The following is a description of a gene set: Mouse Gene Set: GOBP_PROTEIN_CONTAINING_COMPLEX_ORGANIZATION species: Mus musculus Any process in which macromolecules aggregate, disaggregate, or are modified, resulting in the formation, disassembly, or alteration of a protein complex., and this is the list of marker genes: Pnpt1, Aif1, Crtc3, Gemin8, Mcts2, Llgl1, Rpl10l, Kcnf1, Arid1a, Map4, Mtrfr, Odad3, Dnm2, Mzb1, Arf6, Abca1 (ATP-binding cassette, sub-family A member 1), Kcng3, Dnah8, Trappc2, Prmt7 (protein arginine N-methyltransferase 7), Nckap1, Pde4d, Katnb1, Mavs, Flii, Tekt2, Eif3i, Atp5mc2, Kctd1, Pml, Plekha7, Dnajb12, Diaph2, Csnk1d, Per2, Cenpw, Map2, Cptp, Sh3bp1, Rab5if, Aldh1a3, Rpsa, Prkd1, Rpl24, Npm1, H1f6, Micu1, Clta, P2rx3 (NCBI Gene Id 78804), Trappc2l, Capg, Smarcd2, Cav3, Padi4, Rubcn, Pwp2, Trappc3, Gspt1, Med16, Pdcd6, Fus, Wnk1, Ublcp1, Denr (density-regulated protein), Large1, Dstn, Mlst8, Usp4, Capza1b, Ndufa13, Samhd1, Plek, Ndufa10, Cdc42, Pycard, Oprd1, Ube2c, Sorl1, Hes5, Sun5, Cracd (NCBI Gene Id 75147), Trappc5, Cops8, Shank1, Lima1, Sod2, Chmp4c, Fadd, H2-Ea, Kcnj12, Pcdhga3, Map7d3, Bok (BCL2-related ovarian killer), Plec, Rbpms, Traf3ip1, Ptpn11, Lrrk2, Brsk1 (BR serine/threonine kinase 1), Bnip3, Bbof1, Rack1, Capn3, Mtln, Fes, Rictor, Dele1, Stmn4, Pole3, Bend3, Gsdmd, Ryr3, Fscn1, Sar1a, Wdr77, Picalm, Eps8, Prpf18 (pre-mRNA processing factor 18), Pak3, Ggn (gametogenetin), Nrg1, Vps4b, Myadm, Zmynd10, Rcc1l, Myc, U2af2, Coro7, Lyrm7, Tssc4, Trim54, Cenpo, Rp1, Gemin2, Mapk8 (NCBI Gene Id 26419, mitogen-activated protein kinase 8), Syp (synaptophysin), Psmg3, Tmem39a, Ago1, Cntln, Tapbp, Atad2b, Hmgb1, Ccl21b, Usp50, Med23, Med4, Psip1, Rasa1, Ccdc88c, Cenph, Mpp7, Chp1, Dbn1, Brf1, Bin1, Med15, Coa4, Celf3, Uqcrc1, Ikbkg, Naf1, Cbr4, Tubb4a, Hcn1 (NCBI Gene Id 319874), Taf11, Smarca2 (NCBI Gene Id 67155), Card11, Nsg2, Aqp5, Kmt2a, Fmn1, Prex1, Ndufs5, Fnip2, Gtf2h5, Taf7l, Kcnq2 (NCBI Gene Id 16536), Arfgef1, Ppp1r9a, Znhit3, Cd247, Taf10, Tnfaip1, Ndufb11b, Nup35, Raf1, Otx2, Ccdc65, Taf4, Tmem186, Taf12, Tk1, Acvr1c, Axin1, Timm21, Gch1, Hcls1, Tnfsf18, Lrp12, Kcnq3, Slc31a1, Chmp2b, H1f5 (H1.5 linker histone, cluster member), Ddx42, Setx, Clec7a, Pak1, Casp4, Sf3a1, Tmem120b, Kcng4, Mrpl58, Hacd1, Tespa1, Lcat, Kctd2, Eif4g1, Jam3, Crnkl1, Aurkb, Vegfa, Ptger4, Zfand1, Rbmx, Stx1b, Atp6ap1, Mrps7, Uqcc4, Pet100, Nefm, Appl2, Higd2a, Ndel1, Eif2d, Bik, Med21, Sv2a, Mlkl, Erc2, Bbs10, Capzb (capping actin protein of muscle Z-line subunit beta), Bcs1l, Eif3m, Calhm3, Celf5, Hip1, Cfl2, Mdn1, Slc25a46, Tfam, Asb2, Srsf1, Daw1, Pla2g12b, Eif3j1, Basp1, Chmp3, Zfp207, Stx4a, Cox7a1, Kank2, Ncln, Kcna1, Sec16a, Ndufb1, Diaph1, Unc13d, Sh3gl2, Cryaa, Med22, Acacb, Kcns2, Pik3ca, Ddx28, Abca5, Tifa, Prpf3, Adgrl4, Ube2s, Bax, Hsp90ab1 (NCBI Gene Id 98078), Mecp2, Srsf10, Trpm4, Bdp1, Samd1, Pfn1, Wnt10b, Dnaaf10, Bag4, Ppp2r5b, Csf2, Chmp7, Ccdc39, Rad51c, Nlrc3, Higd1b, Pym1, Ssh2, Dmtn, Fermt3, Ifih1, Lyrm2, Hccs, Tmsb15l, Ube2srt, Preb, Kcnd3, Ndufs3, Kcna7, Coro1a, Eef2k, Farsa, Ripor2, Zfp827, Rho, Ccl21a, Chd2, Tnp1, Clns1a, Tcf4, Stk3, mt-Nd4, Mpo, Rnf112, B2m, Nrxn1, Chmp1b2, Ndufs8, Eif5, Vcp (valosin containing protein), Kcnb2, Aimp2 (aminoacyl tRNA synthetase complex-interacting multifunctional protein 2), Eral1, Coa5, Abitram, Actr3, Erc1, Ap1b1, Dkc1, Cenpi, Spef1, Rps27, Kcng1, Prpf6, Fyco1, Csnk1a1, Uqcc3, Shmt2, H1f2, Ndufc1, Cul3, Fermt1, Phf23, Ikzf1, Mapk15, Tubgcp5 (NCBI Gene Id 259278), Alox5ap, Ap2b1 (adaptor-related protein complex 2, beta 1 subunit), Gemin6, Ndufab1-ps, Tubb1, Ndufaf8, Scarb1, C9, Mapk9, Chchd4, Oas1e, Vamp4, Gas7, Nlrc4, Ndufb6, Ndufs2, Stmn1, Srpk1, Hax1, Togaram1, Nol3, Tspyl1, Pcnt, Sdhaf1, Ehd4, Gsdma3 (NCBI Gene Id 450219), Ago3, Nup98, Epn1, Dnah2, Tuba1a, Tmsb15b2, Nr1h2, Apob, Spp2, Nup93, Ubqln1, Unc13a, Fermt2, Lipg, Mical2, Vbp1, Bad, Ifi214, Clasp2, Snap25, Git1, Kctd10, Mis18a, Ptges3l, Fnip1, Bin2, Brix1, Synj1, Trim30a, Tmod4, Dnah7a, Cfl1, Upf1 (UPF1 RNA helicase and ATPase), Bid (BH3 interacting domain death agonist), Camsap3, Cttn, Oip5, Ext1, Tppp3, H1f0, Ckap2, Usp16, Rph3a, Abl1, Ndc1, Dock5, Ttc17, Calr, Lix1, Dmc1, Ric3, Tirap, Snx14, Ripk1, Trem2, Ppp2ca (protein phosphatase 2 (formerly 2A), catalytic subunit, alpha isoform), Prpf39 (pre-mRNA processing factor 39), Trim31, Ndufb2, Nedd1, Casq2, Kirrel1, Pard6b, H1f9, Pip4p1, Vamp3, Dnaaf3, Ankra2, Ninj1, Comp, Ap2m1, Lcmt1, Mapk3, H3f3c, Etf1, Hrk, Lmod1, Ube2k, Ccl24, Eml2, Cenpe, Mospd2, Sh3pxd2b, Stx1a, Ddit4, Kcnd2, Yap1, Srp19, Casq1, Mip, Epb41, Eif3g, Pfdn5 (prefoldin 5), Baiap2, Vps33a, Prpf4b, Adam10, Napb, Esr1, Mrto4, Mbl1, Acot13, Ndufaf6, Ppp1r9b, Gsk3b, Itpr1, Mark4 (MAP/microtubule affinity regulating kinase 4), Pfdn6, Kif21a, Atr, Sdhaf4, Pla2g7, Arhgap28, Kif2c, Chaf1b, Snap91, Hdgfl3, Setd2, Oxa1l, Lrrc8a, Slc1a5, Mttp, Nsf, Hjurp, Ndufs1, Trim21, Arpc4, Nlrp1b, Trim72, Lpl, Specc1l (sperm antigen with calponin homology and coiled-coil domains 1-like), Eif3e, Ankrd53, Slc24a2, H2-Aa, Fer, Nap1l5, Krt10, Trpm6, Pdxp, H2-Eb1, Ndufa1, Mzt1, Shmt1, Ikzf4, Evl, Adrb2, Anks4b, Mettl17, Abt1 (activator of basal transcription 1), Vdac2, Pkd2, Krt1, Chchd10, Mtpn, Ndufa11b, Hopx, Taf5, Rrs1, Dnai2, Cox17, Clint1, Nap1l4, Dhx30, Asf1b, H4c14, Lats2, Dnah7c, Nek7, Plekhg2, Aldob, Glra3, Ruvbl2, Ttbk1, Insr, Unc13b, Shroom2, Pcsk5, Osbpl2, Taf13, Trpa1, Psmd11, Cobl, Brd2, Ptpn22, Taf3, Cadps2, Vil1, Gpihbp1, Cenpa, Ptk2 (NCBI Gene Id 14083), Gmnn, Spast, Chmp4b, Atl1 (atlastin GTPase 1), Calm3, Tlr2, Zdhhc1, Srpk3, Ddx46, Tap2, Cck, Clasp1, Cops7a, Selp, Sppl2c, Col16a1, Lrrc8c (leucine rich repeat containing 8 family, member C), Vwa1, Hprt1, Ifi206, Ssna1, Apc2, Cox18, Ifi213, Hey2, Cp, Fbxl2, Cdc42ep4, Mtor, Mcoln1 (NCBI Gene Id 94178), Kcnc2, Avil, Eln, Kcnn4 (potassium intermediate/small conductance calcium-activated channel, subfamily N, member 4), Hip1r, Apoa5, Pkd2l1, Mtss1, Ccl26, Mical1, Dyrk3, Rsf1, Cdc42ep1, Dact1, Tmod3, Eml4, Riok3, Drc1, Stk4, H2-DMb2, Cep89, Prkn, Ccdc66, H1f1, Ifi208, Psmc6, Arhgef2, Lrrc23, Tecpr1, Map3k7, Col1a2, Cav1, Cby1, Terf1, Calm1, Rims1 (regulating synaptic membrane exocytosis 1), Insm1, Gba2, Sumo1, Elp2, Rsrp1, Kcnc1, Camsap1, Rubcnl, Nap1l2, Clybl, Nfkbiz, Gcfc2 (NCBI Gene Id 330362), Taf1b, Adar (NCBI Gene Id 99861), Dnah7b, Prpf31, Atp23, Lix1l, Med29, Xaf1, Igf1r, Eif3j2, Cox7a2, Smarcd3, Kcna2, Clxn, Stmn2, Chmp6, Rab3a, Hp1bp3, Apip, Apoa2, Creb1, Mefv, Mcu, Ehd3, Tdo2, Smarcb1, Dr1, Rrm1, Luc7l3, Mcm2, Oas1b, Sptbn4, Kif24, Supt6, Kcnv2, Ttc39aos1 (NCBI Gene Id 102642299), Oma1, Tcap, Sh3glb1, Tal1, Fhod3, Micall2, Mid1ip1, Prnp, Plekhh2, Cdc45, Prnd, Ogfod1, Nme7, Pde4dip (phosphodiesterase 4D interacting protein (myomegalin)), Fga, Aldoa, Cdk5rap2 (CDK5 regulatory subunit associated protein 2), Rpf2, Spta1, Ankrd27, Tgfb1, Grwd1, Arl2, Tenm1, Med31, Atxn7, Ubqln4, Tpx2, Taf2, Med24, Sf3a3, Cenpj, Trim11, Pik3r2, Add3, Trpm1, Rhoa, Gldc, Cutc, Trpv6, Ccl21d (C-C motif chemokine ligand 21D), Kcna10, Kcnt1, Prkdc (protein kinase, DNA activated, catalytic polypeptide), Crp, Hemk1, Sirt2, Nefl, Gspt2, Dkk1, Klhl12, Prkra, Pnlip, mt-Nd2, Ctnnbip1, Abcg2, Ugt2b1, Ndufs6, Gtf2b, Nde1, Zdhhc9, Ndufb7, Zw10, Ica1, H2-Oa, Ndufaf2, Bbs4, Cyfip1, Dlgap5, Ambra1, Als2, Odad4, Med18, Faf1, Fkrp, Tmc8, Shkbp1 (NCBI Gene Id 192192), Oga, Tppp, Lsm4, Snap29, Irgm1, Cth, Orc4, Trpv5, Rims2, Vtn, Aifm1, Svip, Nr4a1, Ndufa5, Kcns1, Med10, Coil, Cenpt, Anp32b, Dbnl, Wnt3a, Dnah17, Ifi209, Clip1, Smn1, Snrpf, Twnk, Ccl21f (C-C motif chemokine ligand 21F), Arhgef1, Apoa1, Bcl2l11, Nop53, Svil, Tmem199, Pik3c3, Cyren, Kcnb1, Hsd17b8, Surf1, Hck, Arhgef5, Cfap70, Kctd12, Skap1, Set, Hscb, Mtrf1l, H2-Eb2, Kcns3, Brf2, Prmt5 (protein arginine N-methyltransferase 5), Med7, Atpaf2, Zc3h12a, Tead2, Hnf1b, Ralb, Hspa4, Rsph9, Fau, Cxcl13, H1f4, Dut, Kcnc4, Gabarapl1, Tbcel, Elavl1, Nemf, Blm, Ccdc40, Otud6b, Ttc12, Eif5a2, Rrn3, Tfap4, Ahr (aryl-hydrocarbon receptor), Crtc2, Ndufs4, Myd88, Lmo4, Fech, Ndufb10, Tbp, Jmjd6 (NCBI Gene Id 70547), Lzts3, Cltrn, Fxr1 (NCBI Gene Id 99741), Tln1, Psmg1, Rbmxl1, Rpl11, Hspa8, Wdr47, Smim20, Gtf2f2 (NCBI Gene Id 68705), Pet117, Snupn, Nup153, Mapre1, Pmfbp1, Stxbp6, Uqcc5, Ssrp1, Clec16a, Ehd1, Eif5a, Apoc1, Sar1b, Carmil1, Atf1, Vps4a, Tbc1d25, Rps5, Pias1, Mapre3, Slain1, Stmn3, Pnliprp1, Pf4, Dnah1 (NCBI Gene Id 630521), Sem1, Nup210 (nucleoporin 210), Epg5, Cdc42ep2, Cep57, Trpv4, Vmp1, Ski, Gchfr, Bmerb1, Ang, Casp1, Macroh2a1, Scaf4, Abca7, Med20, Luc7l, Oas1d, Kif18a, Hspa1a, Letm1, Tpm1, Kctd21, Iapp, Abhd17a, Hes1, H1f3, Taf8, Klc1, Dnm1l, Dnaaf4, Wdr1, Syngr3, Kif18b, Ndufc2 (NADH:ubiquinone oxidoreductase subunit C2), Snapin, Scaf8, Pecam1 (NCBI Gene Id 97748), Rad51, Gas2l1, Coa8 (NCBI Gene Id 73501), Snrpert, Il5, Mid1, Met, Nacc2, Isg15, Ndufaf7, Cltc, Cib1, Cd36, Ces1g, Arf1, Sub1, Slc25a33, Sox9, H2-Ab1, Alox15, Srprb, Smarca5, Rps28, Camsap2, Fgb (NCBI Gene Id 67908), Snap23, Eif3f, Cox14, Mndal, Ndufa6, Gm12250, Birc2, Elp6, Mcmdc2, Dnaaf2, Pogz, Chrac1, Dnm1 (dynamin 1), Nopchap1, Smyd3, Nup133, Smcr8, Hsp90aa1, Zmpste24, Ssh1, Kctd16, Farsb, Tmod2, Pih1d2, Celf6, Twf2, Tppp2, Ticam1, Prf1, Nup54, Immp2l, Trappc4, Tafazzin, Tmsb4x, Snrpb, Nin, Eif3b, Spag1, Gemin5, Srsf12, Grin1, Supt16, Asph, Rps6-ps4, Gabarap, Sost, Kctd11, Rps14 (NCBI Gene Id 99773), Kctd7, Yju2, Rpl23, Swap70, Atp5f1d, Sigmar1, Caly, Ccdc103, Zbtb1, Ifi207, Kctd6, Atp5mc3, Taok1 (NCBI Gene Id 67240), Nap1l3, Aqp11, Cdh17, Kif2b, Asf1a, H2-DMa, Thg1l, Hsf1, Ndufs7, Vps35, Nlrp3, Gemin4, Dnaaf1, Lonp1, C2cd6, Tnf, Kctd5, Farp2, Carmil2, Cyld, H2-DMb1, Tmem223, Dlg4, Ajuba, Aida, Dlg1, Fastkd2, Adrm1b, Afg2b, Mtrf1, Tmem170, Trappc6a, Dhx9, Dnaaf6rt, Gria3 (NCBI Gene Id 73036), Fastkd3, Ythdc1, Ptges3-ps, Hgsnat, Pkd1, Aldh9a1, Kcna3, Grin2b, Tbcd, Syk, Cpsf6, Daxx, Rrp7a, Pif1, Taf7, Akain1, Ect2, Ttn, Ulk1, Cldn7, Fbxo5, Rpl38, Tspyl5, Syt11, Zdhhc5, Sf3a2, Kcnk13, Chaf1a, Acad9, Trappc1, Smarcd1, Snrpe, Bmf (NCBI Gene Id 99362), Itln1, H3f3b, Pom121, Akap9, Chaer1, Ncbp1, Ccsap, Lamc1, Snu13, Pik3r4, Srpk2, Ssbp3, Arpc5l, Ooep, Kcna6, Eif3h, Mmp3, Fcho1, Ccdc115, Kank3, Puf60, Pxdn, Tarbp2, Hrg, Tdrd6, Calhm1, Alad (aminolevulinate, delta-, dehydratase), Nphs1, Cyba, Max, Akap5, Snrpg, Smarcc1, Smarca4, Pnliprp2, Kank1 (NCBI Gene Id 77823), Stxbp1, Capn1, Ptk2b, Irgm2, Pink1, Kat6a, Eif3k, Ano6, Pex5, Traf2, Sptan1, Dnal1, Shprh, Myo1c, Drg1, Kif9, Capza2, Syt1 (NCBI Gene Id 20979), Arhgef7, Tubgcp3, Pdcl, Stmp1, Dnajc9, Atp1a3, Gemin7, Fmc1, Spty2d1, Src, Taf1c, Dnaaf11, Gnmt, Ccl11, Tbcc, Med9, Tfip11, Cyria, Fcho2, mt-Nd5, Hspa5, Dmd, Hdac6, Map1s, Nlrp6, Higd1c, Prkce, Rs1, Nav3, Myh9, Med26 (mediator complex subunit 26), Timmdc1, Cfap73, Pltp, Rom1, Cln3 (NCBI Gene Id 12752), Cenpx, Fas, Daam2, Ikbke, Eif4h (NCBI Gene Id 52314), Foxred1, Aldh1a2, Nvl, Dhx29, Abca3, Trim65, Ruvbl1, Cox15, Nufip1, Tspyl2, Psmd9, Med8, Esam, Dnai1, Eid2, Psmd5, Grb2, Nubpl, Bbc3, Gak, Rnf135, Znhit6, Cox20, Vill, Eif6, H2al2a, Clip3, Odad2, Slc39a12, D1Pas1, Macroh2a2, Btk, Lipc, Spidr, Khdc4, Cenpv, Gpx4, Pdzd11, Ddx3x, mt-Nd6, Tmem126b, H1f8, Gtf2a2, Tmem70, Pla2g3, Cx3cl1, Gnl3l, Gbp5, Ulk4, Slc1a2, Mfsd8, Me1, Tpr, Clu, Map1lc3b, Ugt1a1, Prune1, Luc7l2, Itgb1bp1, Eif2s3x, Adcy8, Tubgcp2, Map1lc3a, Rdx, Otol1, Ndufa9, Ifi203-ps, Snap47, Cfap100, Angpt1 (NCBI Gene Id 68823), Cand2, Mbnl1, Jchain, Kctd15, Coa6, Cep192, Nop2, Was, Dnlz, Acsl3 (acyl-CoA synthetase long-chain family member 3), Taf6l, Tmem120a, Dnaaf6, Pkm, Upb1, Med17, Mcm3ap, Mdm4, Fam107a, Vamp2, Sting1, Zfp746, Mis12, Dnajc6, Pdia3, Stub1, Smarcc2, Ssbp1, Rrm2, Atat1, Eif3l, Snrpd3, Uqcc2, Tspan33, Atp6v1b1, Tubg2, Med27, Lgals3, Slf2, Tlr4, Oas1g, Nup205, Atl2, Myo5a, Tgm2, Mat2a, Cd2ap, Nckap1l, Kif14, Nck2, Rhoc, Bop1, Cd3d, Dyrk1a, Strap, Cops7b, Rap1b, Tapbpl (NCBI Gene Id 213233), Mbd2, Chmp2a, Hsd17b10, Ndufb4b, Mmp1b, Washc1, Ifng, Capza1, Cyrib, G3bp2, Smad7, Hcfc1, Vamp8, Nr1h4, Tmem35a, Htatsf1, Cd74, Rpl13a, Crbn, Celf1, Vamp1, Acaca, Pomp, Nudt21, Ndufb4, Steap4, Cenpk, Mfsd2a, Trpm7, Mcur1, Ice1, Arid2, Soat1, Psmg4, Apoe, Peg10, Rac1, Lefty1, Ndufb5, Prpf19, Rps15, Cdc42ep3, Add1, Gbp2b, Zfp148, Sycp1, Fchsd1, Eif2ak2, Megf8, Wdr72, Tfrc, Msrb1, Uqcc1, mt-Rnr2, Rad52 (NCBI Gene Id 19365), Ogt, Gabarapl2, Ripk2, Zdhhc12, Atp2a2, Nlrp5, Efr3a, Celf4, Baiap2l1, Mgrn1, Bmncr, Gm14137, Ckap5, Ddx39b, Chmp1b, Tmod1, Ndufb3, Prkcd, Scin, Sco1, Srpra (signal recognition particle receptor alpha), Med19, Isy1, Catip, Bcl10, Kctd8, Trp53bp1, Afdn, P2rx7, Med30, Tbca, Ddx20, Snx9, Med28, Dnajc15, Eif2s2, Itpr3, Rtn4 (NCBI Gene Id 68585), Tubg1, Abce1, Pef1, Ssh3, Sptbn1, Dhx33, Ncam1, Hira, Atm, Golga2, Csf3, Vstm5, Kntc1, Det1, Tubgcp4, Atrx, Jmjd4, Kcnv1, Rhod, Seh1l, Eif3a, Dgat1, Fn1, Chrna3, Napa, Mat1a, Trp73, Ndufaf1, Cdk1, Pfn3, Calm2, Gkn2, Rps25, Apoa4, Kctd9, Wdcp, Uvrag (UV radiation resistance associated gene), Cxcl12, Map6d1, Rims3, Samm50, Smarce1, Wars1, Coa3, Mgp, Taf1, Ndufa11, Calcoco2, Gls, Sdhaf3, Rbm5, Cldn1, Cox10, Dab2ip, Scara5, Tom1, Kcna5, Sart3, Mybpc3, Oas1f, Ahctf1, Pla2g5, Sptb, Snca, Bbs12, Rps3, Mpp2, Eps15, mt-Rnr1 (NCBI Gene Id 17724), H2bc1, Lin54, Cdt1, Oas1c, Cd24a, Rnf4, Nasp, Rasip1 (NCBI Gene Id 69903), Htr1a, Nap1l1, Inpp5j, Ubn1, Kctd13, Trpm2 (NCBI Gene Id 97643), Atg12, Pfn5, Yme1l1, Fgg, Baiap2l2, Chmp5, Lmod3, Lrrc61, Cpsf7, Gtf2a1, Wasl, Cenpn, Diaph3, Pfn2, Map1b, Tubgcp6, Hspa1b, Rab3gap1 (NCBI Gene Id 69346), Polr1e, Cyfip2, P2ry12, Lcp1, Med11, Trhr, Ccn2, Best1, Gemin6-ps, Myh11, Arpc2, Sds, Psrc1, Cryab, Sf3b1, mt-Nd1, Sugt1, Fgf13, Rap1gds1, Dnai3, Chmp1a, Map1a, Nckap5, Slc2a1, Mrm2, Ndufaf3, Trp63, Atl3, Taco1, Ep300, Kcnj8, Senp6, Tbce, Washc5, Uqcc6, Shfl, Wdr19, Opa1, Slc9a1, Dnajc17, Fblim1, Eif3d, Ndufb8, Med1, Isl1, Lsm2, Ryr1, Capza3 (capping actin protein of muscle Z-line subunit alpha 3), Usp39, Thra, Htt, Higd1a, Cfap57 (NCBI Gene Id 77131), Rps19, Sgtb, Pdgfc, Actn2, Prpf8, Sgta, Plagl2, Cdc42ep5, Msrb2, Dnah5, Crtc1, Nlrp1a (NCBI Gene Id 435266), Ppid, Tlr6, Slain2, Cryz, Trim32, Nsg1, Ndufa3, Foxc2, Aar2, Pdcd6ip, Becn1, Dlgap3, Tmem242, Eif2s3y, Rps27l, Cotl1, Gas2l2, Ndufab1, Ccl21e, Nup107, Slu7, Scaf11, Card9, Cox16, Ush1c, Pih1d1, Irak3, Vma21, Trappc11, Arhgap18, Kat6b, Pex14 (peroxisomal biogenesis factor 14), Prmt8, Septin2, Dnajb14, Celf2, Rsph4a, Ptges3, Unc13c, Kif5b, Vasp, Kcnj2, Igtp, Eif4ebp1 (NCBI Gene Id 13685), Xab2, Tiam1, Spmip6, Tmem126a, Prph2 (NCBI Gene Id 19133), Nck1, Zfp777, Ms4a1, Homer1 (NCBI Gene Id 26556), Med25 (NCBI Gene Id 75613), Tspyl4, Ces1d, Cct2, Frey1, Plcg2, Trabd2b, Stoml2, Mitf, Rps6, Cdkn1b, Ndufaf4, Sco2, Snrpd1, Prlr, Mcts1, Dab2, Atpaf1, Mapt, Tmem9, Add2, Taf9, Gbp2, Lats1, Abcg1 (NCBI Gene Id 11307), Map3k1, Mif, Tm9sf4, Kctd3, Ndufa8, Coa7, Cenpp, Arc, Otof, Psmg2, Icam1 (intercellular adhesion molecule 1), Fhdc1, Ndufaf5, Zrsr2, Gda, Psmd10, Faf2, Kcnd1, Prkcz, Arpc5, H2ac25, Apcs (amyloid P component, serum), Haus2, Clp1, Twf1, Soat2, Apoc3, Ndufa2, Ttc19, Cebpg (NCBI Gene Id 14749), Krt5, Sfswap, Brk1, Numa1, Kcnc3, Kank4, Tead1, Ndufb11, Stx17, Aqp4, Atad2 (ATPase family, AAA domain containing 2), Chd1, Ptbp2, Lamp2, Rbbp4, Ago2, Polq, Fkbp4 (FK506 binding protein 4), Dmac2, Clec2i, Krit1, Oas1a, Mical3, Cdh5, Pla2g2e, Baz1a, Tns3, Ecpas, Ndufb4c, Apom, Adrm1, Washc3, Naa60, Taf6, Rpl5, Ndufb9, Eif3c, Kctd19, Kcnrg, Snrnp200 (NCBI Gene Id 9996), Ago4, Brcc3dc, Sdhaf2, Vps16, Trpv1, Ahsg, Clgn, Cideb, Gpaa1, Eif4b, Septin8, Mdm2, Lpcat3, Ccnb1, Park7, Trp53, Ccdc63, Mkks, Pla2g10, Ugdh, Prrt2, Lrrc8d (NCBI Gene Id 75118), Kctd4, Fchsd2, Sgk1, Dnaaf5, Med6 (mediator complex subunit 6), Dmac1, Shq1, Aim2, Xrcc5, Arhgap40, Nckap5l (NCBI Gene Id 380969), Gsn, Atg14, Aqp2, Arpc3, Nupr1, Itgb3bp, Kcna4, Dctn1, Cox19, Apc, Arl6, Chchd7, Kif19a, Col6a1, Taf4b, Dnai4, H2-M3, Ccdc57, Mmp1a, Snrpd2, Lmod2, Oas1h, Gria2, Prmt1, Nes, Cdc123, Msn, Snrpc, H2-Ob, Tbcb, Gba1, mt-Co3, Brcc3, Dicer1, Tgfbr3, Cenpc1, Trim9, F2rl1, Atg5, Piezo1 (NCBI Gene Id 234839), Bak1, Med14, Cand1, Trim6, Srsf6 (NCBI Gene Id 98904), Sema5a, Cadps, Cox7a2l, Slit2, Slf1, Ttbk2, Trappc12, Bmyc, Ifi203, App, Tspan4, Stxbp5, Odad1, Dlg5, Mcat